The following is a description of a gene set: Human Gene Set: MIR4774_3P Genes predicted to be targets of miRBase v22 microRNA hsa-miR-4774-3p in miRDB v6.0 with MirTarget v4 prediction scores > 80 (high confidence targets). from publication Chen Y, Wang X (PMID 31504780) species: Homo sapiens, and this is the list of marker genes: FARP1, ABCA5, CCP110, ZIC3, TPD52L2, FRMPD2 (NCBI Gene Id 414180), SERPINB2, AOX1, FBXW2, SPART, RBM25, SMAP2, SAYSD1, PNN, SETD3, NPHS1, ALKBH3, KDM7A, BEAN1, UACA, HRH1, RNF128, TLX2, ACTR3B, ABRA, CHML (CHM like Rab escort protein), SEMA3A, DNAJB4, BAZ1B, ERVW-1, ZMAT4, FBXO48, NMBR, CLTC, POU3F2, PURG, ENTREP1, ANO1, MARK3, ATRNL1, TSC22D2, ELOVL6 (NCBI Gene Id 79071), TENM3, PCDH9, ADAMTS3, CEP350, PROX1, GOLPH3L, COCH, HINT1, UBE2W, UBE2D1, SORT1, ANGPTL5, TFB1M, TRIM71, ST8SIA4, IL1RAP, RPS6KB1 (NCBI Gene Id 6796), CLK4, SOWAHA, DPYSL5, RPA1, GRIP1, GLIPR1L2, UBE2Q2 (ubiquitin conjugating enzyme E2 Q2), GNAQ, OR51E1, SAMD9, VPS13C, SLC39A12, IGIP, NCOA4, SLC6A8, USP31, SP100, AMFR, PEA15, SET, TSHZ2, RMND5A, KLHDC1